The following is a description of a gene set: This event has been computationally inferred from an event that has been demonstrated in another species.<p>The inference is based on the homology mapping from PANTHER. Briefly, reactions for which all involved PhysicalEntities (in input, output and catalyst) have a mapped orthologue/paralogue (for complexes at least 75% of components must have a mapping) are inferred to the other species. electronically inferred by orthology from the curated human pathway part of: Cytosolic sensors of pathogen-associated DNA  species: Mus musculus Reactome Pathway: LRR FLII-interacting protein 1 (LRRFIP1) activates type I IFN production, and this is the list of marker genes: Irf3 (interferon regulatory factor 3), Ep300, Ctnnb1 (catenin beta 1)